The following is a description of a gene set: studied in species Mus musculus Mouse Gene Set: GOMF_POSTSYNAPTIC_NEUROTRANSMITTER_RECEPTOR_ACTIVITY Neurotransmitter receptor activity occurring in the postsynaptic membrane during synaptic transmission., and this is the list of marker genes: Ly6h, Grik4, Chrnb1, Chrng, Gabra2, Gabra3, Lypd6b, Gabrg2, Ly6c2, Ly6e, Grik5, Chrne, Gabrb2, Grm1, Kctd16, Drd5 (dopamine receptor D5), Lypd1, Tmem35a, Chrna10, Chrna9, Pate4, Spdye4a, Gabra1, Ly6g6e, Glra2, Chrm3, Gabbr1, Ly6g6g, Chrnb4, Htr3b, Ly6m, Gabrb1, Chrm4, Ly6g6d, Gabre, Grik2, Gabra5, Chrna5, Drd2, Gria4, Gabrg3, Chrm2, Grm5, Spdye4b, Ly6g2, Slurp2, Grin2c, Gria2, Anxa9 (annexin A9), Gria3, Ly6g, Gabrd, Grik1 (glutamate receptor, ionotropic, kainate 1), Drd4, Ly6a, Chrna1, Ly6f, Grid1, Grin3b, Chrnd, Gabra4, Kctd12, Drd1, Grin2d, Lypd6, Chrm1, Adrb1, Glra1, Chrna4, Gabrb3, Grid2, Ly6c1, Gabra6, Chrnb3, Chrm5, Chrna6, Slurp1, Gabrr2, Grin3a, Grin1, Grin2b, Gria1, Chrna7, Grin2a, Lynx1, Htr3a, Psca, Ly6i, Agrn, Drd3, Glrb, Cdk5, Chrnb2, Grik3 (NCBI Gene Id 329940), Chrna2, Chrna3